The following is a description of a gene set: Abdominal wall muscle weakness Human Gene Set: HP_ABDOMINAL_WALL_MUSCLE_WEAKNESS Decreased strength of the abdominal musculature. studied in species Homo sapiens, and this is the list of marker genes: CYP27B1, PIGQ, SMCHD1, PTEN, SKI, ANXA11, MAP2K2, FRG1, CAPN3, DUX4L1, VDR (vitamin D receptor), GYG1, HNRNPA1, DUX4, DNMT3B, GNPTAB, NF1